The following is a description of a gene set: species: Homo sapiens An abnormality of the metabolism of folic acid, which is also known as vitamin B9. Human Gene Set: HP_ABNORMALITY_OF_FOLATE_METABOLISM Abnormality of folate metabolism, and this is the list of marker genes: TCN2, PNPLA8, RNU4-2, ZNF699, HLA-DQA1, HLA-DQB1, MTR, DHFR, SLC46A1, SLC19A1, SPTBN1, AMN, FTCD, OTUD5, CUBN